Given this list of marker genes CD36, MIR105-1, TLR2 (toll like receptor 2), TLR6, CD14 (CD14 molecule), here is a description of the gene set: studied in species Homo sapiens Human Gene Set: GOBP_RESPONSE_TO_DIACYL_BACTERIAL_LIPOPEPTIDE Any process that results in a change in state or activity of a cell or an organism (in terms of movement, secretion, enzyme production, gene expression, etc.) as a result of a diacylated bacterial lipopeptide stimulus.